Given this list of marker genes UBR2, ING2, SLC2A8, FOXJ3, HSPA2, CCNA1, HSF2BP, RPL10L, RAD51C, MYBL1, DDX4, BRDT, MOV10L1, UBB, MEIOC, DMC1, SYCP3, REC8, DMRTC2, MEIOB, BTBD18, BRCA2, TRIP13, DNMT3L, SPO11, SLC25A31, ZSCAN21, FOXJ2, TDRD9, here is a description of the gene set: Human Gene Set: GOBP_MALE_MEIOSIS_I studied in species Homo sapiens A cell cycle process comprising the steps by which a cell progresses through male meiosis I, the first meiotic division in the male germline.